Given this list of marker genes Chmp4c, Vps4b, Chmp1a, Nedd4, Mvb12a, Chmp6, Vps37b, Chmp3, Chmp7, Lrsam1, Chmp2a (NCBI Gene Id 68953), Tsg101, Chmp1b2, Vps4a, Pdcd6ip, Chmp4b (charged multivesicular body protein 4B), Chmp1b, Chmp5 (charged multivesicular body protein 5), Mvb12b, Chmp2b, here is a description of the gene set: Mouse Gene Set: GOBP_VIRAL_BUDDING studied in species Mus musculus A viral process by which enveloped viruses acquire a host-derived membrane enriched in viral proteins to form their external envelope. The process starts when nucleocapsids, assembled or in the process of being built, induce formation of a membrane curvature in the host plasma or organelle membrane and wrap up in the forming bud. The process ends when the bud is eventually pinched off by membrane scission to release the enveloped particle into the lumenal or extracellular space.